The following is a description of a gene set: Genes up-regulated in comparison of immature NK cells versus intermediate mature NK cells. Previous reports have defined three subsets of mouse NK cells on the basis of the expression of CD27 and CD11b. The developmental relationship between these subsets was unclear. To address this issue, we evaluated the overall proximity between mouse NK cell subsets defined by CD27 and CD11b expression using pangenomic gene expression profiling. The results suggest that CD27+CD11b-, CD27+CD11b+ and CD27-CD11b+ correspond to three different intermediates stages of NK cell development. species: Homo sapiens from publication Chiossone L, Chaix J, Fuseri N, Roth C, Vivier E, Walzer T (PMID 19234143) Human Gene Set: GSE13229_IMM_VS_INTMATURE_NKCELL_UP, and this is the list of marker genes: KIF1A, FAM43B, MESP1, PPP2R3A, TFDP1, HOGA1, TBXT, PWP2, PSD2, ST8SIA4, RBM14, BRCA2, HIRIP3, MAZ, RAMP1, HSD11B2, TMEM132E, CTSF, BICDL1, CIMIP2A, ADAM8, PDCD1LG2 (NCBI Gene Id 80380), ZCCHC13, SHISA2, DKKL1, CLVS2, SIDT1, FAM43A, LMNTD2, NOL4, NSG2, VIPR1, SLAMF6, ADGRG3, IL20RA, CD27, ATP12A, C8B, LINS1, NPPA, BEND7, MAN2A2, GPAM, KRTAP3-1, SMCO3, SOX6 (NCBI Gene Id 84363), BFSP2, PCDHA12, PKN1, RNF144A, TSR1, ADGRG5, ZNF593, TSHZ2 (NCBI Gene Id 7765), FIRRE, ADH4, ERICH6, OGFR, KIT, IRF4, MBOAT1, CCDC70, IGHM, PENK, HABP2, TOM1L1, EGR4, GFAP, KAZN, ACTRT2, SGSM1, PARP12, SREBF2, SCN1A, CYB561, PDK1, CES4A, TLR6, CAVIN4, REN, MBP, TMEM179, DLGAP1, SEPTIN8, MCF2L, CXCR3, TMIE, SLC6A13, NEURL1, FRMD4B, ADAM12, INSRR, HOXA5, TG, SOX30, LMX1A, NAT14, ARHGEF10, PDZD9, HSPB2, CALR3, CIMIP6, TMEM176B, NEFH, SRCAP, PAX8, RADIL, LALBA, STK4, PLCD1, ZBTB18, KIAA1549, BLTP2, METTL27, SPATA31F1, SLCO3A1, CDH5 (NCBI Gene Id 1003), ANO3, KIF9, TRDN, DDX21, HSPA5, DBF4, RANBP10, CCDC28B, SHH, CTHRC1, ABCA5, CFAP43 (NCBI Gene Id 80217), PYY, STARD4, CHCHD10, DCDC2B, UNC13C, NOC3L, CMTM7, TTC9B, SPINT2, MMP10, NFATC2, RIOK1, FGR, CLCN3, MISFA, DPP4, TUBA8, FCHSD2, SERINC2, PHF13, PDGFA, CYFIP1, CCKBR, CSTA, TNFAIP8, AK8, TACC2, IL1F10 (interleukin 1 family member 10), RAI1, USP50, TCAF1, LPAR1, A2M, IKZF2 (IKAROS family zinc finger 2), UBE2H, PRDX6, CDH23, ITGB3, SLC24A3, KCND3, GAS8, APBB2, GPIHBP1, FEN1, C19orf81, NNAT, CA4, MS4A6A, LGI3, TMEM18, ARMH3, CHEK1, EGLN3, PATJ, ELMO3, ACSF2, MCOLN3, GP2, C11orf16, FHL5, C4orf36, CA2, SMCO4, CDON, CCNE2, GPR161, RGMA, NR0B2, PKN3 (protein kinase N3), KCNN4, PKP4